Given this list of marker genes Scnn1a, Aifm1, Scnn1g, Scnn1b, Nr3c2, Sgk1, Ace, here is a description of the gene set: Mouse Gene Set: GOBP_CELLULAR_RESPONSE_TO_ALDOSTERONE Any process that results in a change in state or activity of a cell (in terms of movement, secretion, enzyme production, gene expression, etc.) as a result of an aldosterone stimulus. studied in species Mus musculus